Given this list of marker genes MCM2, H2BC5, PSMD11, DBF4, ANAPC1, H2AJ, PSMA4, H2BC26, PSMA7, GINS2, PSMD1, CDC26, PCNA, PSMA5, H2BC17, RPA4, PSMB3, CDC16, H2BC9, PSMD3, LIG1, H3C15, ANAPC10, H2BC3, UBE2D1, ANAPC4, UBE2C, CDK2 (cyclin dependent kinase 2), GINS1, DNA2, PSMA6, H2BC1, H4C1, PSMD13, LIG3, GINS4, PSMD14, POLD4, CDT1, MCM4, CDC23, PSMB1, PRIM1, RFC4, KPNA1, MGME1, POLD1, GMNN, PSMB6, PSMB2, H2AC7, ANAPC5, H2AZ2, PSMA2, RFC2, POLG2, H2BC21, POLD2 (DNA polymerase delta 2, accessory subunit), CCNE1, H2AC4, PSMC6, PSMC5, MCM7, H2BC14, POLA1, PSMB5, ORC6, PSMD6, RPA1 (NCBI Gene Id 6117), KPNB1, POLA2, SEM1, TWNK, POLE2, MCM8, PSMC3, ANAPC11, PRIM2, KPNA6, ANAPC7, MCM3, PSMD7, ORC4 (NCBI Gene Id 5000), UBE2S, H2AC14, SKP1, CCNA1, GINS3, H2AB1, EXOG, PSMC2, POLD3, ORC2, FZR1, POLE, ORC3, RFC3, ANAPC2, ORC5, SKP2, UBC, ADRM1, PSMC1, H3C1, H2BC11, ORC1, PSMC4 (proteasome 26S subunit, ATPase 4), MCM6, PSMD2, H2BC12L, RPA2, MCM10, ANAPC16, RBX1, CDC7, PSMA1, FEN1, CCNA2, UBB, H2BC13, H2BC15, CDC45 (NCBI Gene Id 8319), UBA52, PSMD8, H2AC18, CDC6, CUL1, POLE4, POLG, H3-3A, H2AC6, H2BC4, PSMB7 (NCBI Gene Id 5695), POLRMT, H2AX, TOP3A, RPS27A, CCNE2, SSBP1, POLE3, PSMA3, H2AC20 (H2A clustered histone 20), RPA3, MCM5, PSMD12, H2BC12, RNASEH1, PSMB4, UBE2E1, CDC27, RFC1, RFC5, ANAPC15, here is a description of the gene set: Reactome Pathway: DNA Replication Studies in the past decade have suggested that the basic mechanism of DNA replication initiation is conserved in all kingdoms of life. Initiation in unicellular eukaryotes, in particular Saccharomyces cerevisiae (budding yeast), is well understood, and has served as a model for studies of DNA replication initiation in multicellular eukaryotes, including humans. In general terms, the first step of initiation is the binding of the replication initiator to the origin of replication. The replicative helicase is then assembled onto the origin, usually by a helicase assembly factor. Either shortly before or shortly after helicase assembly, some local unwinding of the origin of replication occurs in a region rich in adenine and thymine bases (often termed a DNA unwinding element, DUE). The unwound region provides the substrate for primer synthesis and initiation of DNA replication. The best-defined eukaryotic origins are those of S. cerevisiae, which have well-conserved sequence elements for initiator binding, DNA unwinding and binding of accessory proteins. In multicellular eukaryotes, unlike S. cerevisiae, these loci appear not to be defined by the presence of a DNA sequence motif. Indeed, choice of replication origins in a multicellular eukaryote may vary with developmental stage and tissue type. In cell-free models of metazoan DNA replication, such as the one provided by Xenopus egg extracts, there are only limited DNA sequence specificity requirements for replication initiation (Kelly & Brown 2000; Bell & Dutta 2002; Marahrens & Stillman 1992; Cimbora & Groudine 2001; Mahbubani et al 1992, Hyrien & Mechali 1993). studied in species Homo sapiens